Given this list of marker genes TNKS, SGO1, HASPIN, NAA10, CDCA5, CHTF8, NIPBL, MACROH2A1, BUB1, MAU2, BOD1, RAD21, SMC3, NSMCE2, STAG1, DSCC1, PDS5B, NAA50, SMC5, RB1 (NCBI Gene Id 92728), HDAC8, POGZ, STAG2, CDC20, SLF1, SLF2, ESCO1, SMC1A, ESCO2, ATRX, PDS5A, here is a description of the gene set: studied in species Homo sapiens Human Gene Set: GOBP_MITOTIC_SISTER_CHROMATID_COHESION The cell cycle process in which the sister chromatids of a replicated chromosome are joined along the entire length of the chromosome, from their formation in S phase through metaphase during a mitotic cell cycle. This cohesion cycle is critical for high fidelity chromosome transmission.